Given this list of marker genes Kif9, Kif21a, Kif28, Nde1, Ywhae, Klc4, Kif13a, Kif17, Kifc3, Kifap3, Kif7, Kif1c, Kif13b, Kif21b, Kif3b, Kif27, Kif18a, Kif2b, Kif3c, Pafah1b1, Disc1, Kif5c, Kif20a, Kif22, Kif20b, Klc2, Kif1b, Kif15, Kif19a, Kif12, Kif1a, Kif18b, Kif2c, Kif2a, Borcs5, Kif5a, Kif23, Kif19b, Kifc2, Klc1, Kif5b, Ndel1, Kifc5b, Kifc1, Kif16b, Kif14, Kif3a, Kif6, Klc3, here is a description of the gene set: Mouse Gene Set: GOCC_KINESIN_COMPLEX species: Mus musculus Any complex that includes a dimer of molecules from the kinesin superfamily, a group of related proteins that contain an extended region of predicted alpha-helical coiled coil in the main chain that likely produces dimerization. The native complexes of several kinesin family members have also been shown to contain additional peptides, often designated light chains as all of the noncatalytic subunits that are currently known are smaller than the chain that contains the motor unit. Kinesin complexes generally possess a force-generating enzymatic activity, or motor, which converts the free energy of the gamma phosphate bond of ATP into mechanical work.